Given this list of marker genes BCL9L, EFHC1, ITGAV, ANKRD39, MTTP, PIBF1, SMAD7, GALNT18, FKBP14, SMAD5, LBH, PCDHB15, FHL2, AMMECR1, KBTBD2, APBB1, HIBCH, COPZ2, PLPP5, ADAMDEC1, ZFHX4, PLPP4, HCFC2, THSD7A, JHY, RRAD, SEMA6A, ASAH2, FAM114A1, MTMR11, TEAD3, SYDE1, ANTXR1, GFPT2, NCS1, CREB3, P3H3, IRX2, IREB2, DOC2B, SH3BP5, LYNX1, IL18, SEC24D, THBS1, PMEPA1, KRTAP19-3, MR1, SKIC3, TRAF7, FLVCR2, OAZ2, FAF2, TSPAN6, ALX1, ABL2, SLC35A2, BRD3OS, SGCE, ANKRD17, DVL2, HIC1, MT2A, ATXN10, BYSL, PPP2R2A, RBM11, SLIT2, NAP1L1, CSAD, TGIF2, ARHGAP24, F13B, GRM5, MXRA7, TWIST1, GLRX3, RGS4, TMEM129, KITLG, GOLM2, USP9Y, DRG2, GFRA4, RNPC3, GLIS2, GAL3ST4, CERS4, PLD2 (NCBI Gene Id 5338), SEMA3C, ARHGAP44, AMPD3, HSPB1, TATDN1, TSPAN4, DYNC2I1, MED13, DNAAF9, KLK8 (kallikrein related peptidase 8), NFKBIZ, PEX11A (NCBI Gene Id 95687), ZNF334, SAA1, CC2D2B, DUSP1, QSOX2, DCLK1, SKP1, S100A16, TNKS1BP1, ECHDC2, TCEAL1, PRKN, GTF3C4, AAK1, CBX6, LIN7A, SDC2, IGFBP6, MMP2, LCLAT1, CREB3L2, SPACA4, USP19, BICC1, AHDC1, LRRC73, GPR6, FBXO3, KLK10, FER, CHID1, GSTM1, ARHGAP29, BOC, BRSK1, STEAP4, CNIH1, FGF7, ERAS, CNRIP1, HS2ST1, PCBP4, PHLDA3, ARMCX4, CDKL3, TBC1D19, CHSY3, HSPB2, DPEP1, SERTAD4, MORF4L1, ACYP2, CEMIP, RETN, DLG5, FAM161A, SOS1, GATA3 (NCBI Gene Id 84828), CCN4, TDO2, CDC16, CGREF1, IPO4, HSPA2, GNL3L, LAPTM4B, PLCG1, SAA2, SERPINI1, GKAP1, RNF214, PEX13, FBXO41, FAM83H, LTA, SRFBP1, TBC1D12, DNALI1, NPLOC4, FAM170A, ZKSCAN1, CD8B, CD81, TMEM14A, PXYLP1, CSF1, TMEM9, LZTS2, EPDR1, BMPR1A (bone morphogenetic protein receptor type 1A), UGCG, VSTM2A, COPS7A, ZNF560, DENND2B, TRIL, TNXB, OSBPL5, IKBIP, here is a description of the gene set: studied in species Homo sapiens from publication Kaji T, Ishige A, Hikida M, Taka J, Hijikata A, Kubo M, Nagashima T, Takahashi Y, Kurosaki T, Okada M, Ohara O, Rajewsky K, Takemori T (PMID 23027924) To obtain insight into the genetic basis of the increase of functional activity of memory B cells over time, we compared the gene expression profiles of day 7 and day 40 NP-specific/IgG1 memory B cells, GC B cells and plasma cells in immunized WT mice and naïve B cells, before and after activation in vitro. Human Gene Set: GSE11961_FOLLICULAR_BCELL_VS_MEMORY_BCELL_DAY40_DN Genes down-regulated in follicular B cells versus day 40 memory B cells.